Given this list of marker genes Wnt3a, Lef1, Dct, Akna, Fgf13, Aspm, Dock7, Fgfr1, Lrp6, Numb, Tead3, Fgfr2, Sox5, Rab10, Arhgef2, Numbl, here is a description of the gene set: Mouse Gene Set: GOBP_NEUROBLAST_DIVISION The process resulting in the physical partitioning and separation of a neuroblast into daughter cells. A neuroblast is any cell that will divide and give rise to a neuron. species: Mus musculus